Given this list of marker genes Cyp2c37, Cyp3a41a, Cyp3a44, Cyp3a59, Cyp2c38, Cyp17a1, Cyp1a2, Cyp1a1, Cyp2c65, Cyp1b1, Cyp2c29, Cyp2c66, Cyp3a13, Cyp3a41b, Cyp3a16, Cyp2c39, Cyp2c50, Cyp3a25 (cytochrome P450, family 3, subfamily a, polypeptide 25), Cyp3a11, here is a description of the gene set: Mouse Gene Set: GOMF_ESTROGEN_16_ALPHA_HYDROXYLASE_ACTIVITY Catalysis of the reaction: estrogen + reduced + O2 = 16-alpha-hydroxyestrogen + oxidized + H2O. species: Mus musculus